Given this list of marker genes Ube2f (NCBI Gene Id 98459), Lyz3, Gzmb, Alkbh1, Mymk, Slc6a17, Nectin1, Lhfpl1, Stum, Trip6, Fam163b, Ppp1r9b, Smco1, Cbx6, Nt5dc1, Csnk1g1, Wfdc6a, Nfasc (neurofascin), Pef1, Map3k13, Scg2, Usp50, Zdhhc15, Isl1, Tbc1d23, Sncb, Slc22a27, Kmt2a, Pknox2, Zfhx2, Glmp, Alx4, Frmd7, Clns1a, Tmem63a, Fgfr4, Smap1, Lama3, Ccdc68, Tomm34, Pde1b, Atf7, Dpp6, Mex3a, Col1a1, Irx5, Dlk1, Bin1, Tdrd3, Shisa9, Snapin, Lrrc58, Actb, Tbc1d7, Bloc1s5, Zfp646 (zinc finger protein 646), Zfp36l2, Mink1, Abca5, Nek8, Lhx6, Zfp637, Atg7, Ube3a, Tbc1d30 (NCBI Gene Id 77450), Cyp2u1, Srgap3, Wfdc6b, Cdhr1, Mrpl50, Sox6, Nfix, Rps6kc1, Slc18a1, Ppard, Dhdh, Klf13, Gng11 (guanine nucleotide binding protein (G protein), gamma 11), here is a description of the gene set: from publication Chen Y, Wang X (PMID 31504780) studied in species Mus musculus Genes predicted to be targets of miRBase v22 microRNA mmu_miR_6941_5p in miRDB v6.0 with MirTarget v4 prediction scores > 80 (high confidence targets). Mouse Gene Set: MIR_6941_5P